Given this list of marker genes PRKAR1A, TBXT, NOTCH2, GNPTAB, HAAO (3-hydroxyanthranilate 3,4-dioxygenase), SLC35B2, DDRGK1, GLB1, NODAL, SLC35D1, SIX6, RPS19, NFIX, POC1A, DDR2, FLNB, COMP, KIAA0586, SLC26A2, FN1, GALNS, BGN, CSPP1, LONP1, RMRP, VANGL2, TRIP11, IARS2, IDUA, CCL2, ACVR1, MNX1, DYM, POGZ, TRPV4, AIFM1, NSDHL, VANGL1, EBP, FUCA1, FUZ, WNT7A, SUMF1, LFNG, SLC29A3, EXTL3, TP63, GNS, FGD1, ARSL, COL11A1, RAB33B, ARSB, FANCL, TNFRSF11A, SOX2, COG4 (component of oligomeric golgi complex 4), GUSB, LBR, NOG, POLR3A, RINT1, PTH1R, INPPL1, ROR2, EIF2AK3, COL2A1, TRAPPC2, FANCB, SF3B2, SOX9, ZIC3, CLCN3, TCIRG1, here is a description of the gene set: Aplasia/Hypoplasia involving the vertebral column Human Gene Set: HP_APLASIA_HYPOPLASIA_INVOLVING_THE_VERTEBRAL_COLUMN species: Homo sapiens